Given this list of marker genes HS6ST1, NFU1, ANOS1, L1CAM, SPAST, WDR45B, MT-ATP8, CYP7B1, SEMA3A, SPART, ABHD16A, RASA1, STXBP1, KLC2, PDHX, SPG21, ZFYVE26, FEZF1, MTRFR, SPRY4, ATP5F1A, FGFR1, KIF1A, UBAP1, LRP12, VAMP1, ELOVL1, ABCD1, AIFM1, VCP, IBA57, RNF220, ALS2, REEP1, ATP5F1E, PEX3, WDR11, CYP2U1, TTR, TECPR2, VPS37A, DCC, ABCA12 (ATP binding cassette subfamily A member 12), TACR3 (tachykinin receptor 3), SETX, SP110, B3GALT6, DUSP6, SAMD9, ARSI, SPG11, GJC2, ATPAF2, MECP2, NIPA1, RILPL1, MAG, MAN2B1, B4GALNT1, REEP2, WDR48 (NCBI Gene Id 57599), CCT5, ENTPD1, SPTAN1, USP8, NT5C2, GPT2, NOTCH2NLC, FARS2, GAN, ASCC3, LYST, GBA2, PGAP1, PLP1, TOE1, SELENOI (NCBI Gene Id 85465), DSTYK, ZFR, KDM5C, MARS1, RAB3GAP2, GBE1, HACE1, KPNA3 (NCBI Gene Id 3839), FLRT1, FLRT3, PROK2, TFG, KIDINS220, ATP13A2, HSPD1, AP4M1, FGF17, C19orf12, AMFR, AMPD2, RAP1GDS1, SLC25A15, WASHC5, CCDC141, SLC2A1, HPDL, KIF5A, ARL6IP1, DDHD1, CPT1C, ERLIN2, FA2H, PAX3 (paired box 3), RNF170, ATL1, PAH, SOX10, RTN2, PI4KA, GBA1, SLC33A1, ATP5F1D, LAMB1, CACNA1D, ALDH18A1, NDNF, ATP5MC3, UCHL1, KY, PNPLA6, MT-ATP6, AP4S1, DNM1L, NAGS, FGF8, SLC16A2, ATP5MK, HESX1, RNASEH2B, CHD7, AP5Z1, ATRX, CKAP2L, AP4B1, SPG7, INTS8, DDHD2, CAPN1, PROKR2, GIPC1, AP4E1, BSCL2, IL17RD, OPA1, here is a description of the gene set: Human Gene Set: HP_PARAPLEGIA studied in species Homo sapiens Severe or complete weakness of both lower extremities with sparing of the upper extremities. Paraplegia